The following is a description of a gene set: studied in species Mus musculus The migration of cells in the telencephalon from the subventricular zone to the olfactory bulb in which cells move orthogonally to the direction of radial migration and do not use radial glial cell processes as substrates for migration. Mouse Gene Set: GOBP_TANGENTIAL_MIGRATION_FROM_THE_SUBVENTRICULAR_ZONE_TO_THE_OLFACTORY_BULB, and this is the list of marker genes: Srf, Slit1, Ogdh, Slit2, Lrrk2, Rac1, Fgfr1, Robo1, Arx